Given this list of marker genes Gpx7, Plk1, Asxl1, Ranbp2, Cytip, Eif4e, Foxn1, Ing2 (NCBI Gene Id 69260), Exo1, Mdm2, Lzts1, Rnf8, Mad1l1, Myc, Apex1, Atm, Pold1, Wif1, Trp53, Cul9, Nf2, Prdx1, Recql4, Dgkd, Arid4a, Usp44, Met, Bub1b, Lats1, Prf1, Cdc37, Pdgfra, Fdxr, Sptbn1, Smarcb1, Prkar1a, Dclre1a, Ssbp2, Bub1, Kras, Htatip2, Pik3ca, Pms2, Pinx1, Smurf2, Cdkn2b, Ifng, Fen1, Trim62, Hic1, Atad5, Srpx, Cdkn2a, Slc33a1, here is a description of the gene set: Mouse genes annotated to increased sarcoma incidence (MP:0002032) retrieved from the Mouse Genome Informatics database via MouseMine Mouse Gene Set: MP_INCREASED_SARCOMA_INCIDENCE from publication Motenko H, Neuhauser SB, O'Keefe M, Richardson JE (PMID 26092688) studied in species Mus musculus